Given this list of marker genes ACADM, KCNJ18, ALDH18A1 (aldehyde dehydrogenase 18 family member A1), MT-CO3, CLCNKB, PSAP, VPS13C, FBXO38, CLCN1, PYGM, PGAM2, SMN2, RNASEH1, BSCL2, HTRA2, TFG, GALC, GNAS, OPA3, HNRNPA1, PMP22, TWNK, MPZ, ERBB4, COL1A1, MT-CO1, COL4A1, GIGYF2, AMPD3, PRPH, CADM3, SNCA, HADHB, PHKG1, GLT8D1, HEXB, DPYS (dihydropyrimidinase), ALDH4A1, GFPT1, AR, ATXN3, REEP1, GBF1, CACNA1S, DNA2, MLIP (muscular LMNA interacting protein), PIGG, KY, PHKA1, PON3, GLE1, SOD1, OPTN, GBA1, RTN2, LRRK2, ABCB6, KCNE3, PARK7, UBAP1, FKTN, PINK1, LDHA, TRPM7, DAO, MORC2, CRPPA, STX16, PON2, TARDBP, CCNF, LPIN1 (NCBI Gene Id 23175), HADHA, DLD, CYP17A1, KCNA1, GARS1, STIM1, PUS7, TRPM6, CHCHD10, DNAJC13, FLVCR1 (NCBI Gene Id 559), SQSTM1, OBSCN, MAP3K20 (mitogen-activated protein kinase kinase kinase 20), LAMA2, PHKG2, POMT1, CARMIL2, POLG2, DNAJC6, MATR3, DOK7, NEFL, TRAPPC11, GBE1, GNA11, SLC16A1, SLC12A1, PPARGC1A, FKRP, GFM2, PON1, PHKA2, CAV3, UBQLN2, CHMP2B, GABRA3, ALG14, VAPB (NCBI Gene Id 9217), ATXN1, PFN1, ATP2A1, ANG, ALG2, CHRNE, LRP12 (LDL receptor related protein 12), PHKB, ATP1A1, KPNA3, CASR, TREM2, FIG4, EIF4G1, UNC13A, VPS35, ATXN2, ISCU, GLA, HINT1, MT-ATP6, STT3A, SLC25A4, COL5A1, SLC12A3, UCHL1, CPT2, SH3TC2, VCP, RRM2B, NEFH, GMPPB, FUS, FXN, DCTN1, LAMP2, PFKM, WASHC5, MICU1, RYR1, SVIL, TAF15, DMD, SYNJ1, NEK1, ACADVL, TBK1, KCNJ1, HHAT, MFN2, HPDL, PODXL, ANXA11, PRKN, SCN4A, AMPD1, ORAI1, COL5A2, SMN1, CFAP410, DGUOK, CASQ1, HSPB1, DPAGT1, PYGL, PGK1 (NCBI Gene Id 5230), POLG, FDX2, here is a description of the gene set: Human Gene Set: HP_MUSCLE_SPASM Muscle spasm studied in species Homo sapiens Sudden and involuntary contractions of one or more muscles.